Given this list of marker genes F3, ZNF75D, CLK2, VAMP2, GPX3, MACF1, CRK, IKBKB, TP53, JUND, TMEM135, SF3B4, C1orf54, CASP8 (caspase 8), SUPT6H, COL9A2, OAZ2, SDC4, PLEKHM1, ARID1A, CRTC3, RASSF4, CCL17, MYO1F, FILIP1L, BEAN1, TCERG1, TMEM214, BRD4, IDE, GATAD2A, STAT1, NAAA, DENND4B, ATP2A2, PNPLA6, MMP7, TAX1BP1, CMC2, FTSJ3, NUP85, SCARF1, CLEC4A, FBXW7, ARHGAP1, TMSB15B, SUOX, CHD9, RBBP6, ANKS1A, GAK, CFAP20, CHST2, HDAC1, TPST2, HGS, PTPN22, CNOT3, CBR4 (NCBI Gene Id 84869), PLXNA1, RNF44 (NCBI Gene Id 260352), COX8A, ERI2, CCL13, COMMD10, SRSF9 (serine and arginine rich splicing factor 9), TNPO3, VCL, PRKCD, PLAU, PKD1P6, SSRP1, CISD1, PARP12, NSMCE4A, ZYX, TYK2, GBF1, IL2RG, AMPD2, POLR2J4, TRAF3IP3, DDX39B, ALDH9A1, AFDN, JAK2, CST3, LIN7C, NRDC, USP47, TLN1, PSMC5, TMX2, PKM, LYRM2, TBC1D5, CBX4, CHCHD2, MLEC, TBC1D2B, CLEC5A, CLASP1, PTBP1, ICAM1, PLXNB2, ZNF512B, CASS4, SH3TC1, SH3GLB2 (NCBI Gene Id 56904), GAN, SLC20A1, MTPAP, SMG7, NACC2, LAMB3, TM9SF2, LUC7L2, EIF5, RAB4A, OS9, XIST, MYO9B, FZD7, RAF1, CAPN1, ERCC5, UMPS, TBC1D10B, RERE, DDX60, TAPBP, TCF4, FHOD1, OTUD4, LSP1, IPO9, CLOCK, DVL3, EIF4G1, PILRB, HCK, GRINA, WSB1, PRCC, LASP1, SOCS5, FKBP3, SRSF5, ADISSP, FKBP1A, C2CD2, BICD2, KAT6A, MAP2K2, COA1, KMT2A, VAMP1, PSME3, RTN1, CYP2B6, GCFC2, KDELR1 (KDEL endoplasmic reticulum protein retention receptor 1), FASN, YEATS2, SKAP2, ASAP1, HECTD3, SIRT6, UBXN7, CENPT, RIPK1, PKN1, GORASP1, GASK1B, WIPI1, RNF170, HIGD1A, TFEC, VWA8, COQ8A, POP5, CLN5, COPS7A, WBP2, NID2, POLR2J, STAG3L1, AAK1, FSCN1, PRKACA, LRP10, CRYBG3, MICB, TNFSF10, PLIN3, QPCT, MED15, MAP7D1, KIF16B, here is a description of the gene set: species: Homo sapiens Genes up-regulated during primary acute viral infection in CD8A dendritic cells: wildtype versus IFNAR1 knockout. Human Gene Set: GSE45365_WT_VS_IFNAR_KO_CD8A_DC_MCMV_INFECTION_UP Murine Cytomegalovirus (MCMV) infection leads to early activation of various immune cells, including B and T lymphocytes, before the actual initiation of antigen-specific adaptive immunity. This activation is partly driven by innate cytokines, including type I interferon (IFN), which are induced early after infection. The objective of this study was to address the role of type I IFN in shaping early/innate B and T cell responses to a primary acute viral infection. In order to decipher the specific impact of IFN-I on cell subsets, we performed a genome-wide expression analysis on WT splenic B and CD8 T lymphocytes isolated from C57BL/6 mixed bone marrow chimera mice. This study complements series GSE39555, which focused on early responses of NK cells and of the two subsets of conventional dendritic cells.